The following is a description of a gene set: Mouse Gene Set: GOBP_MYOFIBROBLAST_DIFFERENTIATION studied in species Mus musculus The process in which an undifferentiated cell acquires the features of a myofibroblast cell., and this is the list of marker genes: Parp1, Tgfbr1, Pdcd4 (programmed cell death 4), Trp53inp1, Fosl2, Rxfp1, Rb1, Tsku